The following is a description of a gene set: studied in species Mus musculus The formation of a covalent cross-link between or within protein chains. Mouse Gene Set: GOBP_PEPTIDE_CROSS_LINKING, and this is the list of marker genes: Cstdc3, Krt10 (NCBI Gene Id 319382), Csta2, Csta1, Stfa2, Tgm2, Evpl, Anxa1, Krt1, Tgm3, Ivl, Col3a1, Tgm1, F13a1, Sprr1a, Thbs1, Stfa2l1, Abca7, Stfa1, Cstdc6, Dsp, Fn1, Loricrin, Csta3, Cstdc5, Cstdc4, Krt2, Stfa3